The following is a description of a gene set: Mouse Gene Set: GOBP_NEGATIVE_REGULATION_OF_LUTEINIZING_HORMONE_SECRETION Any process that stops, prevents, or reduces the frequency, rate or extent of the regulated release of luteinizing hormone. studied in species Mus musculus, and this is the list of marker genes: Tacr2, Oprk1, Crhr2, Oprm1, Crh, Ucn2